Given this list of marker genes APIP, GOT1, ADI1, MRI1, ENOPH1, MTAP, here is a description of the gene set: Methionine salvage is a sequential pathway of six reactions that create methionine from 5'-methylthioadenosine (MTA) which is a byproduct of polyamine biosynthesis in nearly all organisms. The process happens completely in the cytosol. It is important in humans for recycling of sulphur that has to be assimilated using energy. part of: Sulfur amino acid metabolism Reactome Pathway: Methionine salvage pathway species: Homo sapiens